Given this list of marker genes Macroh2a1, Tert (telomerase reverse transcriptase), Ruvbl2, Cct6a, Mir208b, Cct4, H1f5 (NCBI Gene Id 56702), Acd, Ctcfl, Terf1 (NCBI Gene Id 21749), Tcp1, Cct2, Pot1a, Cct5, Pot1b, Spidr, Spdya, Cct3, Lrwd1, Macroh2a2, Nipbl, Zfp827, Dkc1, Nabp2 (NCBI Gene Id 69917), Brca2 (breast cancer 2, early onset), Wbp2, Cct8, Cct7, Wrap53, here is a description of the gene set: Mouse Gene Set: GOBP_ESTABLISHMENT_OF_PROTEIN_LOCALIZATION_TO_CHROMOSOME studied in species Mus musculus The directed movement of a protein to a specific location on a chromosome.